The following is a description of a gene set: studied in species Mus musculus Mouse Gene Set: chr2A3, and this is the list of marker genes: 2810430I11Rik, Mir3967, Gm13325, Npdc1, Ssna1 (SS nuclear autoantigen 1), Carlr, Entpd8, 1810012K08Rik, F730016J06Rik, Ndor1, Spopl, Rnf208, Ccdc187, 1810059C17Rik, Gm13539, Snhg7os, Man1b1, Tmem250, Dnlz, Ralgds, 4921504E06Rik, Nebl, Mir126b, Gm14441, Gfi1b, Gm13360, Pmpca, Gm13337 (NCBI Gene Id 637235), Gm22879, Gm13328, Gm13409, Gm13349, Obp2b, Lcn6, Fcna, Slc2a6, Gm13331, Fcnb, Gm13421 (NCBI Gene Id 105244102), Arhgap21, Gm13326 (NCBI Gene Id 383665), Gm13386, Gm13416, Fcnaos, Traf2, Mastl, Adamts13, Gm13375, Tubb4b, Fam163b, Sec16a, Sohlh1, Tbpl2, Ak8, Surf4, Tmem203, Gm24134, Mrpl41, Grin1os, Ajm1, A930004D18Rik, Lcn10, Pnpla7, Ubac1, Gm13361, Brd3, Egfl7, Wdr5, Camsap1, Fbxw5, Brd3os, Enkur, Zmynd19, Mir3087, Pierce1, Surf1, Ppp1r26, Gm13398, Nxph2, Tmem210, Ptgds, Slc34a3, Gm13348, Lcn4, Rpl7a, Gbgt1, Anapc2, Pdss1, 4930426L09Rik, Il1rn, Gm13370, Tsc1, Gm13394, Cfap77, Barhl1, Hnmt (NCBI Gene Id 99068), Gm17171, Med22, Gm22675, Gm13342, Surf2, Gm13542, Il36b, Gad2, Yme1l1, Dph7, Abca2, Gm25147, Gm24875, Olfm1, Cacfd1 (calcium channel flower domain containing 1), Mllt10, Dipk1b, Commd3, Card9, Gtf3c4, Gm13417, Bmi1, Ehmt1 (NCBI Gene Id 77683), Gm13392, Gm13562, Sh3d2c-ps1, Bmyc, Mymk, Sapcd2, Otud1, Gm13350, Snora17, 0610009E02Rik, Stkld1, Nacc2, Gm13355, Dnajc1, Nrarp, Fut7, A230005M16Rik, Lcn11 (NCBI Gene Id 227630), Gm13415, Apbb1ip, Mir3088, Gm22572, Stpg3, Spaca9, Lcn9 (NCBI Gene Id 77704), Pip4k2a, Ccdc183, Obp2a, Arrdc1, Gm13359, Mrps2, H2al2a, Surf6, Gm13397, Lcn8, Entr1, Gm13344, Gm13369, Gm13378, Dpp7, Nsmf, Mir7578, Thnsl1, Gm13363, Tor4a, Tmem141, Gm13322, Gm13352, Gm13333, Gm13418, Qsox2, Lhx3, Grin1, Spag6, Gpsm1, 1700092C17Rik, Entpd2, Cimip2a, Gm13332, Potegl, Uap1l1, Edf1, Gm13387, C8g, Psd4, Msrb2, Vav2, Ptf1a, Lcn15, Notch1, Dbhos, Abo, Cacna1b, Mir6996, Gm13379, Gm3363, Etl4, Gm13396, Rxra, Gm24886, Rabl6, Gm13341, Mir7655, Gtf3c5, Snapc4, Nelfb, Clic3, Phpt1, Kcnt1, Lcn3, Gpr158, Pax8 (NCBI Gene Id 18510), 4930447M23Rik, Col5a1, Lrrc26, Cel, Gm13377, Gm25541, Adamtsl2, Rnf224, 1810010K12Rik, Rpsa-ps9, Ttf1, Lcn12, Myo3a, Gm13372 (predicted gene 13372), Gm13423, Gm13338, Gm13422, Lcn5, Gm13410, Cysrt1, Mamdc4, Gm13433, Tprn (NCBI Gene Id 97031), Rexo4, Noxa1, Gm23969, Inpp5e, Ddx31, Gm13323, Glt6d1, Acbd5, Il1f10, Gm13553, Sardh, Mir7664, Snora43, Il36rn, Gm24670, Armc3, Abi1, Gm13373, Mir126a, Gm10134, Paxx, Gm33940, Mir6419, Dbh, Gm13347, Il36g, Agpat2, Ptf1aos, Gm13351, Skida1, Il36a